Given this list of marker genes Ano3, Ano4, Plscr4, Ano6, Ano9, Ano7, here is a description of the gene set: The movement of a population of phospholipid molecules from one leaflet of the plasma membrane bilayer to the opposite leaflet as a result of a calcium stimulus. studied in species Mus musculus Mouse Gene Set: GOBP_CALCIUM_ACTIVATED_PHOSPHOLIPID_SCRAMBLING